Given this list of marker genes Gda, Dpyd, Urah, Urad, Uox, Xdh, here is a description of the gene set: Mouse Gene Set: GOBP_PURINE_NUCLEOBASE_CATABOLIC_PROCESS The chemical reactions and pathways resulting in the breakdown of purine nucleobases, one of the two classes of nitrogen-containing ring compounds found in DNA and RNA, which include adenine and guanine. studied in species Mus musculus